Given this list of marker genes DKK3, SNAI2, SCAP, MALRD1, GFI1, INSIG1, NR0B1, WNT4, NFKB1 (NCBI Gene Id 4790), REST, DKKL1, BMP5, MIR548P, C7orf50, MIR98, ERLIN1, MIR185, MIR30C1, INSIG2, ERLIN2, MIR33A, SNAI1, ATP1A1, APOE, PROX1, GGCX, MIR342, PDE8B, FGF19, BMP2, here is a description of the gene set: species: Homo sapiens Human Gene Set: GOBP_NEGATIVE_REGULATION_OF_STEROID_BIOSYNTHETIC_PROCESS Any process that decreases the frequency, rate or extent of the chemical reactions and pathways resulting in the formation of steroids, compounds with a 1,2,cyclopentanoperhydrophenanthrene nucleus.